The following is a description of a gene set: studied in species Homo sapiens Genes in the cancer module 13. Human Gene Set: MODULE_14, and this is the list of marker genes: FGF2, TNFSF12, TNFAIP2, TBXT, FGF1, ANGPT1, IL18, MMP19, CXCL8, FGF6 (NCBI Gene Id 2251), NRG1, EPAS1, ANPEP, JAG1, VEGFD